Given this list of marker genes TMEM126B (transmembrane protein 126B), NRP1, BAIAP2L2, SP8, NEK10, LINC00173, PRDM1, RBP4, ELF4, TMEM37, ISL1, SOSTDC1, DBF4, APCS, RLIM, SYNE4, F2, DNAI4, KLK13, POU2F1, RXFP2, HNF1B, CDH20, AFM, PKLR, NSMCE3, MARCKS, MRPL43, ANKS1B, PHOX2B, SOX3 (NCBI Gene Id 8256), ZNF362, SHKBP1, FGF7, CHMP2A, NAALADL2, TLE4, ARFGEF1, GRIN2A, PCDH8, A1CF, ARHGAP24, VCPKMT, HOXC6, SEMA4G (NCBI Gene Id 57715), HOXB8, SRSF7, UQCRFS1 (NCBI Gene Id 7386), SALL3, PBX2, SLC18A2, CMTM4, ROBO3, TBR1, ZNF143, JPT2 (NCBI Gene Id 90861), HOXB3, GUCA2A, HOXA3, TBL1X, TCF4, YES1, CES5A, NKX2-2, FGA, EPC2, PRDM12, TMPRSS15, FAM27E5, NCAM1, JADE1, C12orf50, SLC5A4, SERPINA7 (serpin family A member 7), WNT9A, TMED6, PRMT3, RNASE4 (NCBI Gene Id 6038), PHLDB1, SREK1, BTBD3, CLC (NCBI Gene Id 1178), ZFHX3, SGK2, PPP2R2B, IKBIP, CBFA2T2, FGF16, ARPP21, ZNF827, TTLL6, SLC25A40, UBXN10 (UBX domain protein 10), MGAT4C, GPX1, TNS1, ZBTB4, MIOX (myo-inositol oxygenase), C8A, APOM, PROC, ATP2B3, ACVR2A, EMX2, SLC6A5, FAM20C, CSF3, ADAM11, APAF1, ARHGAP12, UBE3A, TOB1, AGR3, SLC25A12, PLS3, SLC13A2, HOXA10, LHX5, EML4, ANXA13, FGB, SLC37A4, CCDC50, GUCY2F, THRA, LINC00671, AFP, RPL35A, SLC22A8, UBALD2, SPATA18, CDH17, NFIX, PREX2, LRRC19, SORBS1, COA3, NECTIN1, ZFP36L1, EGR1, DAAM1, ARL4C, LPP, SUPT16H, RAB3IP, SLC39A14, ASPA, SLC7A9, RBFOX1, HNF1A, HESX1, G6PC1, NDST2, EVA1A, PTGS2, ZEB2, NCKAP5, DMD, DPYD, LRAT, CNTLN, MAB21L2, CDH16, BACE2 (beta-secretase 2), HOXC4, KLF14, LUC7L3, FOXA2, RASA2, SLC1A1, FST, TMCC2, HAVCR1, AQP9, CLIP3, GEN1, CAST, KBTBD12, FLRT1, STC1, ALX1, SLC26A3, SLC44A4, KALRN, VSIG1, SLC17A2, CLOCK, TRPS1, ZFPM2, FOXD3, BUB3, EEPD1, CNTD1, SERPINA4, GJB1, POLR2A, ERRFI1 (ERBB receptor feedback inhibitor 1), SLC12A2, IRX6, RORA, NEO1, LRRFIP2, NOL4L, CGN, HOXD4, DLX1 (distal-less homeobox 1), AQP4, F13A1, CRTC2, SERPINA10, SPINK1, FGFR4, MXI1, SLC7A13, SSH3, PAX2, POU3F3, MIER1, CCDC85B, NLGN2, CNGB3, ANGPTL1, PKHD1, PLA2G4A, KCNK12, GC, TWNK, KCNJ1, GOLT1A, RNF186, HCN1, SSH2, RNF111, SLC5A1, PDZRN4, ST6GALNAC5, FRMD5, ASB4, TBXAS1, PPP2R5C, CPN1 (carboxypeptidase N subunit 1), MINK1, MBNL1, KLB, GUCA2B, TINAG, SIAH3, HABP2, FOXF2, here is a description of the gene set: species: Homo sapiens Human Gene Set: HNF1_C Genes having at least one occurrence of the motif DGTTAATKAWTNACCAM in the regions spanning 4 kb centered on their transcription starting sites. This matches the TCF1 transcription factor binding site V$HNF1_C (v7.4 TRANSFAC).